The following is a description of a gene set: Human Gene Set: WONG_ADULT_TISSUE_STEM_MODULE studied in species Mus musculus from publication Wong DJ, Liu H, Ridky TW, Cassarino D, Segal E, Chang HY (PMID 18397753) The 'adult tissue stem' module: genes coordinately up-regulated in a compendium of adult tissue stem cells. Self-renewal is a hallmark of stem cells and cancer, but existence of a shared stemness program remains controversial. Here, we construct a gene module map to systematically relate transcriptional programs in embryonic stem cells (ESCs), adult tissue stem cells, and human cancers. This map reveals two predominant gene modules that distinguish ESCs and adult tissue stem cells. The ESC-like transcriptional program is activated in diverse human epithelial cancers and strongly predicts metastasis and death. c-Myc, but not other oncogenes, is sufficient to reactivate the ESC-like program in normal and cancer cells. In primary human keratinocytes transformed by Ras and I kappa B alpha, c-Myc increases the fraction of tumor-initiating cells by 150-fold, enabling tumor formation and serial propagation with as few as 500 cells. c-Myc-enhanced tumor initiation is cell-autonomous and independent of genomic instability. Thus, activation of an ESC-like transcriptional program in differentiated adult cells may induce pathologic self-renewal characteristic of cancer stem cells., and this is the list of marker genes: PPP1R13B, SLC12A2, CAVIN3, ZFP90, TMBIM1, MEF2A, IFNGR1, SERPINA3, PPP1R18, LTBP2, ARHGAP32, ACOX1, PTGER4, FHL1, DGKG, TLE1, ADRB2, MYADM, ZBTB20, CADM1, NRIP1, KCNA1, P2RY14, ABCB1, PHTF2, GCH1, CCL5, FRMD6, CALD1, PLXDC2, ABCA1, L1CAM, SOX6, ITIH5, TUBB6, CD244, SMARCA2, USP2, PKIA, F2RL3, TES, ELOVL5, PTOV1, ASAH2, ARHGEF10, AGTR2, FOXP1, ANK3, SFRP1, DNAI4, ATP2A2, ITGAE, MARCKS, VNN1, MYCN, PPFIBP2, LILRB1, VN1R5, ETS2, FKBP9, RGS18, FOXA1, CD34, CAV1, DUSP1 (dual specificity phosphatase 1), KLF6, ARL3, APOBR, GREM1, TMEM176A, SLC41A1, PTH, CNN2, GCAT, RYR2, SH3GLB1, TIMP3 (NCBI Gene Id 7078), MITF, ITM2C, IL18, ASH1L, BAG3 (BAG cochaperone 3), SLCO3A1, CLEC7A, TENM3, CAND2, NICN1, LRRC8A, NDRG1, S100A6, GNB5, TCF4, CBFA2T3, BHLHE40, F2R, TBR1, NDN, SHANK3, FN1, KLRG1, SNX10, EVL, INHBB, PCP4L1, MPDZ, DUSP4, LAMC1 (laminin subunit gamma 1), BEX1, PCDHB15, ALCAM, CTSF, PBX1, TSPAN4, COL1A1, PBXIP1, PHLDA1, COL4A2, FSTL1, MAGED1, LPAR3, HOXA3, EYA2, RRAD, IRF6, FLNB (NCBI Gene Id 8413), PCK2, ABL1, ARHGAP6, REEP3, CAPRIN2, DLC1, NREP, THBS1, IL2RA, RFLNB, UBE2E2, BEX4, LAMB1, DDIT4, SLC1A1, KCNMA1, TOB1 (transducer of ERBB2, 1), ZFP30 (ZFP30 zinc finger protein), ADM, ACTN1, TNFRSF11B, BDNF, THSD1, EPHA5, PAQR7, GPR65, SERPINF1, GRIK1, KLF2, TTC3, COMT, P3H4, CMTM8, DKK3, NCKAP1 (NCBI Gene Id 9864), CPQ, NFKBIA, JUNB, HSPA1A, AK1, HOXA5, F3, ZFPM1, TP53BP1, GEM, IGFBP3, NAP1L3, PXDN, RC3H2, HSPA2, PTPRK, RBP1, TRAF1, DAB2, PURA, HBEGF, IL6, BACH1, MMP17, KLK8, ZNF275, LYSMD3, KLF10, PYGM, LST1, ITSN1, STBD1, EMP1, ROBO1, PTPN12, SLC8A1, MFGE8, FBLN2, NPY2R, GNGT2 (NCBI Gene Id 2793), HOMER2, IER3, VN1R17P, ZKSCAN1, IRF7, CSF2 (NCBI Gene Id 1437), CCL7 (C-C motif chemokine ligand 7), TEK, GRID1, RAB34, LATS2, TXN, NAB2, PGLYRP2, DAPP1, SEMA3E, PEX11A, CDKN1A, SARDH, NEDD9, EBI3, ADGRL4, GSX1, LGR5, CYP2J2, SLC6A15, ASTN1, MPL, IGSF10, ACOT1, SORL1, POSTN, RCAN2, RHOB, KITLG, CLCA3P, DNMT3B, CD59, GLRA3, RHOU, RELN, PTPRCAP, FOXC1 (forkhead box C1), NACC2 (NACC family member 2), GPRC5B, NFIB, HDAC11, COL6A1, COL9A3, VDR, PTTG1IP, C11orf54, GABBR1, THBS4, PRSS23, TMEM176B, ID1, AOC3, HOXC4, TRIM47, NID1, IFIH1, DIP2C, SERTAD1, CEBPD, KHDRBS3, SORCS2, MRPL52, CREBRF, DNAJB2, PIK3C2G, PBX3, DST, PATJ, BGN, PRKACB, STAC, MYL9, MSI2, ADGRE1, CIDEA, CISH, SARAF, MUC4, LGALS3BP, GLUL, SYNPO, CNN3, EFNB2, ELOVL6, MLLT3, ITGB5, NCAM1, DAB2IP, CCN2, TESK1, CD200, IRGM (immunity related GTPase M), RASD1, AFF4, ESYT3, MOXD1, BTG3 (BTG anti-proliferation factor 3), MCOLN2, FERMT2, FOXQ1, GRIA3, PEG3, RILPL1, KLF4, SCN1B, LGALSL, PRKCQ, DUSP2, SDC1, SESN1, CD209, FOSB, JUN, ABCG2, KRT6B, ZEB1, TSC22D1, MFNG, CAVIN2, CASP4, HLX, TRIM44, ENG, PDRG1, HLF, GATM, SYT4, RAB38, PDGFA, GABRG1, DLG3, DGKA, CCL27, ADCY6, PLK2, FLOT1, ID2, EHF, SERPINH1, HMG20A, TMEM98, ZNF521, RAB20, SLURP1, TAC1, COL4A1, PLEK, ENTPD1, TBX1, SPIC, IGF2R, GRIA2, HNF4A, ADARB1, DBP, EPB41L4B, RIDA, RORA, MYLK, CRYBG1 (NCBI Gene Id 6763), MARCKSL1, TINAGL1, LSM14B, NRCAM, ARMCX2, IL15, ABCG1, RAI14, ADGRD1, CSF2RA, MEIS1, IL1B, CPHXL, FOS, ATF3, NKX2-3, P3H3, KIT, MYOC, RAI1, UNC5C, PIGR, RETREG1, JAK1, GABRA3, IL1R1, ZFP1, FYN, TAGLN3, PDE2A, TCEAL9, ADGRG1, KLF9, SENP6, CBR3, EGR2, STMN3, PRKCE, CHRNB1, PPP1R9A, ZNF23, DUSP8, AHRR, RCAN3, DPT, APOE, TAGLN, MDFIC, SMAD1, PHLDA2, EMB, NR2F1, BTG2, KMT2A, P2RX4, PADI4, ABHD8, ACTR3B, ADAMTS1, CXCL2, CD1D, VLDLR, MAN1A1, KDELR3, SLC3A2, PRKCB, MSN, STAT4, RRAS, KAZALD1, PGAP4, ETNK1, CRIM1, LAMA2, GJA1, EIF1, SLC9B2, S100A1, NID2, PTPN21, SOCS2, EPHA7, PHC1, STK17B, TRPC6, THA1P, NR4A2, RGS5, CACNA2D1, HLA-DMA, TTPA, ENAH, RGS2, PDE8A, MYO5C, YES1, DOCK7, NR4A1, GSTK1, TPST1, NDRG2, MYH3, CEROX1, ARMCX4, PTGER3, DMD, HOXA9, IMPACT, ESAM, STXBP1, MPRIP, UGDH, CYP1B1, CLIC4, IFI44, SLC6A6, CACNA2D2, ISG15, SLC35E4, NBEA, PMEPA1, PLEKHA5, CERS4, LPP, PER1, RAB11FIP5, DNTT, HTRA1, ZMYM4, SLC39A8, APP, RABEP1 (NCBI Gene Id 9135), EPS8, OSBPL1A, CXXC5, TNC, IL11RA, ARHGEF5, GLIS2, PHF13, LRRFIP1, KLRB1, PNRC1, LY75, IFIT1B (interferon induced protein with tetratricopeptide repeats 1B), KMT2E, CD40, KTN1, LPIN1, DBNDD2, TFAP2B, PLXNA2 (NCBI Gene Id 80253), CAMK2B, AKTIP, ZMYM6, NFIX, RAB27A, NSG2, ICAM1, KCNK2, S100A13, MYO1B, FLT3, CBX4, PTN, FGF1, SOX4, GADD45G, TNFAIP6, DDIT3 (DNA damage inducible transcript 3), SMAD7, MAP7 (microtubule associated protein 7), NUPR1, JUND, GATA2, HOXA2, INVS, DYNLL2, DNAJB4, TENM2, MPZL1, DAPK2, IER2, DTD1, HSPB8, ERRFI1, MUC13, CITED2, PPIC, ANKH, TP53I11, CASP12, TRIM32, ADGRA3, IL18R1, TGIF2, CRIP1, C1R, SCG5, PCLO, DNAJB9, PLPP1, CASQ2, SYTL4, CR2, ZDBF2, GKAP1, HTR2C, KRBA1, NKX3-1, HCAR2, TSPAN6, GJC3, CXCL12, IGFBP7, SKI, GABRR1, NRK, TIE1, TEKT2, REST, VWF, LARGE1, FKBP7, CDKN1C, SIRT3, PLPP3, ABCC1, CYP4V2, TAMALIN, CCND1, SLC66A3, EPHB3 (EPH receptor B3), SASH1, RELB, GABARAPL1, NAV1, SGCE, NPTXR, COL18A1, PKD2, PAIP2B, LTBP3, RBPMS, PHLDB2, TGM2, MAGI2, COL11A1, SSBP2, NR5A1, ARPC1B, LRP4, SNX30, CCL11, FNTB (farnesyltransferase, CAAX box, subunit beta), ID4, LSP1, ARHGAP4, IGFBP5, HOXA10, NCAM2 (neural cell adhesion molecule 2), PHLPP1, NIPSNAP1 (NCBI Gene Id 8508), SMOC2, LTB, PMP22, FOXA3, IL10RB, GATA3, PDLIM3, ZNF503, BARX2, CELSR3, CD27, CCL3, PFN2, CLK1, PLS3, LTBP1, ZMYND11, GPX7, MATN2, SCD, ARHGAP35, LHFPL6, NFKBIZ, RGS4, LGALS1, PDLIM2, CDH2, FZD2, NBEAL2, SPARC, GBP2, ANTXR2, CTSZ, MGST1, TRIB3 (NCBI Gene Id 57761), PRDM5, TAF1D, GNAQ, PACSIN1, TXNDC16, VCAM1, IFITM3, ITM2A, HLA-B, LIMCH1, MACF1, SHFL, ADCY9, DCUN1D1, KCND2, B2M, NCR1, PROCR, FOXN1, ALDOC (NCBI Gene Id 230, aldolase, fructose-bisphosphate C), FGF17 (NCBI Gene Id 8822), LMO2, AMPD3, PTGS2, TAL1, TTC28, RAMP3, CYP7B1, CXCL14, SERPINE1, RHOQ, SPON1, SOCS3, TPM1 (tropomyosin 1), IFNG, TPD52L1, CCN1, SELP, MEDAG, ADGRE5, GNRHR, HSPA1B, RASL10A, KCNA2, ELL2, CNTN1, CEBPB, C1QTNF12, PPP1R15A, STK10, S100A4, CAPN2, RRBP1, CILK1, BASP1, HPGD